Given this list of marker genes KMT5A, RPS6KC1, EPHB2, TAOK1, ARCN1, SPRY3 (sprouty RTK signaling antagonist 3), PTPRD, SEMG2, HGSNAT, TPPP, RAB10, HNRNPA2B1, CNOT1, ADORA2A, SIRT1, RASL10A, B3GNT5, CREB5, FOXC1, NKAPD1, C17orf58, EVA1C, PDE1C, CAPRIN1, EEF1E1, EIF2AK3, ZNF282, NRBF2, PTP4A1, AK4, MON2, RPL7L1, EPHB6, PCGF3, FNIP1, CDH4, RIMS2, PHEX, ADCY1, C2CD2, MLXIP, TOMM70, PLXDC2, M6PR, ACADL, HOXC8, ACER3, RAB22A, BIRC2, PPM1K, LATS1, RHOBTB3, TGFBRAP1 (transforming growth factor beta receptor associated protein 1), ANGPTL1 (angiopoietin like 1), ZFP91, RXFP1, RNF170, ATP8B1, NAA15, EPHA7, PALM2AKAP2, ACSM5, ZBTB20 (NCBI Gene Id 26137), GDNF, SH3PXD2A, ARHGEF33, TMEM237, PRKRA, SGIP1, RPS6KA3, ESRRG, NBEA, SLC43A1 (NCBI Gene Id 8501), TFAP2A, MCCD1, NAA40, ASPH, FRS2, C2orf68, TMOD3, EZR, YPEL4 (NCBI Gene Id 219539), PDCD6, ADCY6, PRAMEF18, BEND6, NR3C1, TMEM87A, ESCO2, TFEC, C9orf72, INTS2, SCN2A, FBN2, HGF, PHF13, ADRA1A, ZNF521, MTMR7, VAPB, SHF, ISM1, MLLT3, ARL8B, XRN1, EFNB3, CRKL, GMEB1, HAPSTR1, TMEM64, MAPRE2, ZNF605, HMCN2 (NCBI Gene Id 727754), PRTG, SOX14, SEPTIN11, NEBL, TOX3, VGLL3, HYCC1, IGF2R, MAGI1, LARP4B, LPP, ASXL3, PCYT1B, RELL1 (NCBI Gene Id 768211), OPRM1, APH1B, CDK14, MAPK9, MTMR6, EXOC6B, ACBD7, RERE, RABGAP1L, CELF2, PTPRT, SCML2, PHOX2B, SPOP, ZKSCAN2, PPARGC1A, YPEL2, DNAJC13, SEC24D, MAP1LC3B, PTPRJ, BRWD1, SLITRK4, HCAR3, ACSL4, IST1, CCDC120 (NCBI Gene Id 90060), SAMD5, ESYT2, FGD5 (NCBI Gene Id 152273), RGL1, ENTHD1, RPS6KA5, THSD4, DPP4, ARHGAP26, TTYH1 (tweety family member 1), KHDRBS3, COX10, ENDOU, AP3M1, ACAT1, EVC2, NCOA7, TSC1, SLC12A6, AQP11, HCAR2, ZFHX4, SLC25A35, AP1S3, DRAP1, TCF12, TRIM44, RHOT1, ONECUT2, CCNY, DHH (NCBI Gene Id 791256), THPO, PRDM1 (NCBI Gene Id 639), SH3TC2, AP1S2, SOS1, TMEM156, AFF1, AEBP2, CAMK1, GPC3, TFAP2B, EBF2, HYAL4, TGFBR2, HLTF, AKAP1, NFATC3, AP2A2, PID1, ZCCHC10, WDR76 (WD repeat domain 76), SASS6, TMEM108, DYRK1A, PKHD1L1, LSM5, NTRK2, ANGPT1, RAB14, IGFBP5, STON2, PPIC, ZFHX3, IL7R, CCNT2, SLC16A6, FUT9, FHIP1B, RUNX2, RASA3, PLXNA2, GAN, PEX19, MGAT3, SPRYD7, TARDBP, DNM2, BTBD1, DYNC2H1, DLG5, AMOT, FAM3B, KLHL29, MYH15, SPRED1, SZRD1, SLC24A2, CPNE8, KCNA3, UGDH, DNAAF9, ARX, MMP16, GNRHR, ELAVL2, ZNF423, NOVA1, ZNF699, FAM168B, BICC1, KXD1, DMTF1 (NCBI Gene Id 9988), GPATCH2L, UBA6, KLF12, FOSB, VWA8, ZBTB7C, WWC3, UBA2, DUSP14, HOOK3, WDFY2, MEIS2, SEC61A2, ABRAXAS2, ITPR1, CHD5, NAPG, RUBCN, BIRC6, TMEM87B, DPF1, TP53INP1, LIG3, LRP2, FZD4, COG5, JPH3, NOP10, TRMT11, VN1R1, GPBP1L1, SSRP1, RREB1, IKZF2, HAPLN1, EPHA5, ANKRD13C, ELAVL3, RAB40B, BMPR1A, GET4, CCDC144A, SLC37A3, RSPO4, ZNF629, GLIS3, CCND2, SKI, ZC3H7A, PIK3CB, CLIP4, GCNT2, PDHX, STOX2, SOX11 (SRY-box transcription factor 11), COX5A, CELSR3, TMEM181, P2RX1, FBXW7 (F-box and WD repeat domain containing 7), PRDM2, FAN1, ALCAM, INO80D, INPP4A, SPCS3, WDR41, FRAS1, NR3C2, TNRC6B, DCUN1D3, ATF2, ANKRD13A, TENT5A, HAS2, CHCT1, ZCCHC24, JARID2, PRRX1, BCL9, CHP1, SOX4, SMIM13, AFAP1, YAE1, CDK13, C2orf76, TMEM213, RTKN2, STXBP5, CHN2, PTPRR, NALF2, SNAP47, SF3B1, FTSJ3, TMEM178B, UBP1, SAE1, PIP4K2B, ST7 (NCBI Gene Id 93655), PRAMEF12 (PRAME family member 12), TMEM263, FRY, UEVLD, RIOK1, NBR1 (NBR1 autophagy cargo receptor), HNRNPUL1, ZNF792, ANO6, SLC25A24, ZDHHC14, GSTM3, MCOLN1, IPO8, FARP1, CD200, JAK2, PERP, KHDRBS1, here is a description of the gene set: Genes predicted to be targets of miRBase v22 microRNA hsa-miR-211-5p in miRDB v6.0 with MirTarget v4 prediction scores > 80 (high confidence targets). species: Homo sapiens from publication Chen Y, Wang X (PMID 31504780) Human Gene Set: MIR211_5P